The following is a description of a gene set: studied in species Homo sapiens from publication Durante MA, Kurtenbach S, Sargi ZB, Harbour JW, Choi R, Kurtenbach S, Goss GM, Matsunami H, Goldstein BJ (PMID 32066986) Human Gene Set: DURANTE_ADULT_OLFACTORY_NEUROEPITHELIUM_RESPIRATORY_EPITHELIAL_CELLS, and this is the list of marker genes: PIGR, C6orf58, BPIFB1, BPIFA1, LYZ, ZG16B (NCBI Gene Id 124220), PIP, STATH (NCBI Gene Id 6779), SCGB1A1, IER3, CAPS, PRB3, SLPI (secretory leukocyte peptidase inhibitor), LTF, DMBT1